Given this list of marker genes Elovl5, Elovl2, Elovl3, Abcd1, here is a description of the gene set: Reactome Pathway: Linoleic acid (LA) metabolism species: Mus musculus This event has been computationally inferred from an event that has been demonstrated in another species.<p>The inference is based on the homology mapping from PANTHER. Briefly, reactions for which all involved PhysicalEntities (in input, output and catalyst) have a mapped orthologue/paralogue (for complexes at least 75% of components must have a mapping) are inferred to the other species. part of: alpha-linolenic (omega3) and linoleic (omega6) acid metabolism electronically inferred by orthology from the curated human pathway